Given this list of marker genes RARA, BMP10, MEF2A, ATG5, MYH10, MYOCD, PROX1, CCNB1, RXRB, RARB, NRG1, NKX2-6, PITX2, FHL2, CDK1, MEF2C, NKX2-5, HEY2, LMNA, here is a description of the gene set: Human Gene Set: GOBP_VENTRICULAR_CARDIAC_MUSCLE_CELL_DIFFERENTIATION studied in species Homo sapiens The process in which a relatively unspecialized cell acquires specialized features of a ventricular cardiac muscle cell. Cardiac muscle cells are striated muscle cells that are responsible for heart contraction. The ventricle is the part of the heart that pumps blood out of the organ.